Given this list of marker genes ASCL1, PHOX2A, HOXB1, UQCRQ, SEC24B, CDK5R1, SCRIB, BCL2, CDK5R2, KCNE1, ATF2, here is a description of the gene set: The process whose specific outcome is the progression of the pons over time, from its formation to the mature structure. The pons lies above the medulla and next to the cerebellum. The pons conveys information about movement from the cerebral hemisphere to the cerebellum. Human Gene Set: GOBP_PONS_DEVELOPMENT species: Homo sapiens